The following is a description of a gene set: Genes containing one or more binding sites for (DNMT3A) in their promoter regions (TSS -1000,+100 bp) as identified by GTRD version 20.06 ChIP-seq harmonization. Human Gene Set: DNMT3A_TARGET_GENES from publication Yevshin I, Sharipov R, Kolmykov S, Kondrakhin Y, Kolpakov F (PMID 30445619) studied in species Homo sapiens, and this is the list of marker genes: ELL2, R3HDM2 (NCBI Gene Id 51220), STK38L, GTF2IP20, GIHCG, CLCN3, PDAP1, AKIRIN1, PHF12, SHLD3 (shieldin complex subunit 3), SHF, CBX3 (NCBI Gene Id 82756), CASP9, CBY1, RNU5A-8P, TTC5, SH3GL1, STK10, ARPC4-TTLL3, CD274, POLR2L, TOB1-AS1, AKAP13, SMC3, TRIM41, LINC02890, GNB1, CCDC18-AS1, NR6A1, ASB16-AS1, OXR1-AS1, SMURF1, TIGD5, PCBP2, PRMT5, KCNAB2, DYNC1LI2, RPL7P41, FKBP1A, ERHP1, LINC01556, CACTIN, ABHD6, RN7SL1, PAWR, PGK1, DGAT2-DT, TSPAN4, PLEKHG2, RNF217, PPP5D1P, MYLK, RIMKLB, MCPH1-AS1, NDUFS7, TRAPPC3, ATMIN, MTERF3, PSMA2P3, GON4L, ZNF628, SEC11C (SEC11 homolog C, signal peptidase complex subunit), ENSG00000238142, CFAP221, CA11, ASAH1, RNASE11, SNORA13, TRAPPC2B, GATC, LSM12, ACTR10, H2BC15, UBE2I, DOK1 (docking protein 1), MYL12B, RARRES2P5, TMEM202-AS1, FARS2, WDR45B, XIAPP3, EWSR1, IBA57, ZNF576, INAVA, RNF19A, RPL21, BLCAP, UBR1, EPHB2, REXO1, IGF1R, DHRS13, SMC2, ZSWIM6, SSU72, CENPP, C6orf52, RN7SK, STX6, RN7SL2, TAF13, C15orf61, RAB28, IBA57-DT, ADGRL2, MTCH1, LINC01600, BRAT1, DOHH, PPP1R13L, CHTF18, MARCHF6, FANK1-AS1, UHRF2, RNVU1-15, LINC02410, PSIP1, TXNL4A, RABEP1, SEPTIN7P13, MAP3K21, COPS7B, LINC02118, SRD5A1, GRIPAP1, MED29, TMPRSS7, UBB, IPO13, SELENOW, TOB1, OXR1, CYP4V2, RFX1 (regulatory factor X1), NPIPB8, HNRNPA1P62, GOSR2, NUP205, IQCH-AS1, SETD5, RNVU1-27, RANBP2, H4C8, RPS29, MAP3K7CL, CAPN8, STK19, PHKA2, MDH1, SETD1A, RPL19, ILRUN, VDAC2, BTBD9, DAP3, IQCH, FAM13B, VARS1, PHC1, EMC10, BZW2, JOSD1, DYNC1LI2-DT (DYNC1LI2 divergent transcript), CFAP96, HCG14, LRRFIP2, FAM227A, LTA4H, LINC03126, ICE1, PFDN4, ENSG00000259617, VTRNA1-3, MAGOHB, ANG, MALAT1, MIR331, SRRM5, RPL23AP7, GPATCH2L, EFTUD2, IRGQ, KRT17, TSPAN31, CDIPT, HADHB, CCDC107, C2orf42, SNX12, UFD1, STK35, ATG16L2, PTP4A1P6, FUS, ARPC4, GNB2, SCAT2, AGBL5, FANK1, NOL8, PPP6R3, ATP1B3, CENPN-AS1, TMEM154, C11orf68, MIA2-AS1, PDIA3P2, PDCD2L, POLR3F, TM9SF1, GLYATL1, GNB1-DT, TRIM7-AS2, EPCIP-AS1, AASDHPPT, DGUOK, CHD2, UBR5-DT, KPTN, CDKL4, RRAS2, MIA2, YAE1-DT, PLD1, G6PD, VDAC2P2, C1D, ENSG00000253699, ITPRIP (inositol 1,4,5-trisphosphate receptor interacting protein), FAM98B, NOP56, HNRNPU, STAM2, OPA3, GARS1, TRAJ38, TCF12, DGAT2, LASP1 (NCBI Gene Id 3927), ANKRD22 (ankyrin repeat domain 22), PEF1-AS1, MLLT10, ITGA9, FLCN (folliculin), CCDC103, BDNF-AS, ARIH1, MIR4757, B4GAT1-DT (B4GAT1 divergent transcript), ACOT7, CDK11A, POT1-AS1, KMT2A, CCT4, CFAP418-AS1, INPP5F (inositol polyphosphate-5-phosphatase F), PNO1, SNORD118, YAE1, CNOT6 (CCR4-NOT transcription complex subunit 6), SEC23B, ATF7-NPFF, EEF1D, GTF2IP12, ESYT2, LCE1C, CDKL3, ATG16L1, COQ7-DT, HSPE1, RPL9, DDX54, KNL1, FBXO33, YY1AP1, FOS, CENPU, TMEM167A, DRAP1, EIF3B, TADA3, RPL12P18, HIGD1AP13, HOMER1, HYAL2, ELOVL5, DUX4L18, ISG15, LOXL3, MNAT1 (MNAT1 component of CDK activating kinase), ALG1, LIMD1-AS1, PAK1IP1, ZNF219, SNX8, MIR5188, LSR, BAZ2B, PPM1L, RNF44, JARID2-AS1, MTND5P11, JARID2, CTNNB1 (NCBI Gene Id 1499), FBXO9, KANSL1, MED16, ZNF891, BCAR3, RAB11B, TMC3-AS1, POLG, CWC25, ZNF300, KICS2, OXSR1, SASH1, ZNF35, C2orf78, MARCHF7, HAUS8, FAP, TJP2, MPST, HSP90AA1, RFFL, BCAP29, HSPE1-MOB4 (NCBI Gene Id 100529241), SLC35E2B, NEK7, ANKMY2, CENPN, BRAF, FN1, CMC2, WARS2-AS1, PLPP5, DBP, LIG4, GARIN5A, TMEM259, ALDH4A1, SRI, SUPV3L1, DPP9, CCDC83, HINT3, MAPKAPK5-AS1, TIMM22 (translocase of inner mitochondrial membrane 22), TGFBR1, RFX3, RNASE4, ADGRF2P, PRMT5-DT, HES4, IFNWP9, JOSD2, SH3D19, PAK1, COMTD1, ANKLE2, FBXL2, ATXN2L, C21orf91, RALGAPA1, PAXBP1, SS18, TRIAP1, LINC01347, UBC, LINC03011, MAP7D1, SRRM2-AS1, GOSR2-DT, POLG-DT, GASAL1, KTN1, MICAL3, ZEB2, MYL12-AS1, RPUSD1, LYRM4, ZNF839, MAP1LC3A, PPM1L-DT, TRAPPC13, THUMPD3-AS1, DOT1L, H2AC15, RBBP8, NUB1, BCL2A1, FAM228A, LRP3, MIR99AHG, COX19, MAP2, TIA1, GARS1-DT, NOTUM, R3HDM2-DT, C19orf48P, ENSG00000265845, EIF2B1, PRMT5-AS1, HSPA6, SPOP, MIR3649, AP2A2, LINC00513, RTF2, KBTBD3, DCTN1, RBM17, HADHA, VTRNA2-1, PSMG2, LINC00431, SRRM2, EEF1E1P1, RRM2B (NCBI Gene Id 50484), POT1 (NCBI Gene Id 25913), DISP3, LAMB1, NFYB, TCP11L2, PSCA (prostate stem cell antigen), RNU5D-1, TST, CD55, MROH8, PLXDC1, IFT80, SLC7A5, RN7SKP52, CDIPTOSP, CETN3, NEXN-AS1, RNU5F-1, DZANK1, BUB1B-PAK6, COMMD1, TRAJ7, RNASEH2A, SACM1L, MYNN, CDON (NCBI Gene Id 50937), NAPA-AS1, CAPRIN1, MIR4999, C2CD5, PTDSS1, EIF4A3, PAXIP1-DT, CDH17, LINC02453, RMRP, CREB1, XPOTP1, TRIM33, MAPKAPK5, CEP76, TMEM250, SUDS3, PEF1, ASAH1-AS1, BRPF1, NDUFA10, ATG101, HSPD1, BCL6, MCRIP2, UFSP2, ILF2, TMEM260, TSN, ALOXE3, ACBD4, PRMT9, MYOM2, POLR1G, RNU6-9, INTU, CTDP1-DT, DNAAF10, HMGN4, FRAT2, LINC02918, KIAA0319L, ATP6V1A, ALDH3B2, LINC02532, POLR2B, NSUN4, GNPTG, RPN2, MYB, LINC01962, MVK, TMUB2, UROS, ZNF10, ABL2, VAPB, WTAPP1, ZNF628-DT, PRP4K, TLE1-DT, SLC6A15, GPCPD1, LINC02564, H4C16, NOCT, WBP4, ZC3H18, CENPB, TPBG, XRCC4, API5, EOLA2-DT, RNF215, USP36, MYO3B, VTRNA1-2, RNU6ATAC, LCP1, PDE6D, CD164, RABL2A, CTU2, GNAS, CCDC85C, TTLL7, FOXJ3, ATAD3B, TRIM23, TLE1, DHX57, CDC14B, SMARCC2, NAGPA, RNVU1-28, RAD23A, GTF2IRD1P1, AAGAB (alpha and gamma adaptin binding protein), DCBLD2, RAPGEF1, LINC01619, JRK, ZNF547 (NCBI Gene Id 284306), COX7A2L, SSR4P1, FMC1, FGF7, EED, WDPCP, RNVU1-6, TDRD7, NSUN2, UPF2, APOA1, GSTA4, CDC45, RN7SL471P, UBA1, ATP9B, METTL25B, CATSPER2, RNF126, GRK3-AS1, PIK3R3, RHBDD3, MIR3929, CD200R1L-AS1, RPL14, ING3, LINC02739 (NCBI Gene Id 105369317), ATP8A1-DT, POLR2M, VPS37B, RAB11A, TARDBP, SHOC1, ATF7, LIAS, ENAH, PSMB3, PDLIM5, FBXO31, MIR4521, ISG20L2, SPDL1, BUD31, PAXIP1 (NCBI Gene Id 22976), CREBBP, MYO9B, LURAP1L-AS1, NDUFB1, FRAT1, HROB, EIF4ENIF1, SPDYA, DHX29, FAM187A, FOSB, SSU72-AS1, PKNOX1, BCCIP, CTDP1, ZBTB21, FMC1-LUC7L2, PPP3R1, RBKS, HJV, KANSL1-AS1, GTPBP10, SNX16, EPB41L4A-AS1, CDK16, EMD, ADARB1, RHOBTB3, VTRNA1-1, RNASEK, SLC27A4, SLC35F3, CHCHD3P1, FAT1, SLBP, CENPE, SCFD2, ILRUN-AS1, NDST2, COL4A6, PDE4A, MBD3, GTF2H3 (NCBI Gene Id 2967, general transcription factor IIH subunit 3), LINC01623, B4GAT1, ARID1B, EOLA2, ENSG00000226097, PDE7B-AS1, RBMXL2, MIOS-DT, GGNBP2, MIR4727, DXO, RITA1, GOLM2, FEM1A, SLC35E2A, MT2P1, ZNF395, AGBL5-AS1, CPSF2, CALM3, NUDT18, CPEB4, DENR, MLST8, ZFAND2B, RMND5B, ATP8A1, ENSG00000255647, KRT6A, TSR3 (TSR3 ribosome maturation factor), RNVU1-14, UBE2B, MAP1LC3B, PHRF1, KRTAP4-6, ALG6, GET3, ZC3H8, RNU4-67P, VTI1B (vesicle transport through interaction with t-SNAREs 1B), MGRN1, PPIL4, KDM3B, HECA, RNU5A-1, DDX18, PROS1, RNASEK-C17orf49, COQ7, RNU5E-1, PWWP3A, LINC02408, NCOA7, RNU4-2, BUB1B, RAD54B, METTL26, PPEF1 (protein phosphatase with EF-hand domain 1), LINC01719, CFAP418, RNF166, PRKCI, GBA1 (NCBI Gene Id 82008), POLR3E, CSNK1G2, SNX14, ING4, LINC00706, SEPTIN7P14, SAV1